Given this list of marker genes PDGFRA, here is a description of the gene set: part of: Drug resistance of PDGFR mutants A number of PDGFRA mutations found in GIST and other cancers are resistant to inhibition with imatinib. These include the most common allele D842V, which occurs in the activation loop of the receptor, as well as S601P and the gatekeeper mutation T674I. studied in species Homo sapiens Reactome Pathway: Imatinib-resistant PDGFR mutants